The following is a description of a gene set: Any process that modulates the establishment or extent of a membrane potential in the depolarizing direction away from the resting potential in a ventricular cardiomyocyte. Mouse Gene Set: GOBP_REGULATION_OF_VENTRICULAR_CARDIAC_MUSCLE_CELL_MEMBRANE_DEPOLARIZATION studied in species Mus musculus, and this is the list of marker genes: Gja1, Gja5, Scn5a, Cav3, Smad7, Gpd1l, Scn3b